The following is a description of a gene set: studied in species Mus musculus Mouse Gene Set: WP_ESTROGEN_METABOLISM Estrogen metabolism, and this is the list of marker genes: Ugt1a2, Nqo1, Ugt1a6a, Sult1e1, Ugt1a9, Cyp1a2, Comt, Ugt1a1, Gstm1, Sult1a1 (sulfotransferase family 1A, phenol-preferring, member 1), Cyp1a1, Cyp1b1, Gsta1